Given this list of marker genes CD40LG, SH2D1A, XIAP, IKBKG (inhibitor of nuclear factor kappa B kinase regulatory subunit gamma), NBN, here is a description of the gene set: species: Homo sapiens Human Gene Set: HP_DYSGAMMAGLOBULINEMIA Dysgammaglobulinemia Selective deficiency of one or more, but not all, classes of immunoglobulins.